Given this list of marker genes Pcyt1b, Apoa1, Pcyt1a, Rab38, Gpat4, Acsl3, Pemt, Fabp3, Slc27a1, Cept1, Chka, Capn2, Chpt1, Lpcat3, Lpcat1, Lcat, Fgf7, Fabp5, Chkb, Apoa2, Dhrs7b, here is a description of the gene set: The chemical reactions and pathways resulting in the formation of phosphatidylcholines, any of a class of glycerophospholipids in which the phosphatidyl group is esterified to the hydroxyl group of choline. studied in species Mus musculus Mouse Gene Set: GOBP_PHOSPHATIDYLCHOLINE_BIOSYNTHETIC_PROCESS